The following is a description of a gene set: The chemical reactions and pathways resulting in the breakdown of mRNA, messenger RNA, which is responsible for carrying the coded genetic 'message', transcribed from DNA, to sites of protein assembly at the ribosomes. Mouse Gene Set: GOBP_MRNA_CATABOLIC_PROCESS studied in species Mus musculus, and this is the list of marker genes: Nrde2, Pcid2, Magohb, Pnldc1, Lsm2, Dnd1, Traf2, Exosc7, Mettl3, Dhx34, Ago4, Mrto4, Tent4b, Zfp36l1, Fastkd5, Rock1, Hnrnpr, Cnot10, Thrap3, Ncbp1, Cpeb3, Alkbh5, Mex3d, Pkp1, Igf2bp2 (insulin-like growth factor 2 mRNA binding protein 2), Arid5a, Fmr1, Caprin1, Upf1, Ttc5, Exosc6, Il17a, Qki, Ago1, Xrn1, Plekhn1, Myd88, Nbas, Rnasel, Hspa1a, Mov10, Mir466l, Mir451a, Gtpbp1, Trim71, Igf2bp3, Nanos2, Dhx9, Cirbp, Lsm14b, Apex1, Cnot1, Fxr2, Meioc, Angel2, Pym1, Mirlet7c-2, Rbm33, Skic2, Dcp1b, Tob1, Mtpap (mitochondrial poly(A) polymerase), Hnrnpd, Brf1, Magoh, Hnrnpu, Dicer1, Gspt1, Eif4enif1, Fus, Vip, Elavl4, Vim (NCBI Gene Id 22352), Elavl1, Slfn14, Larp1, Lsm4, Piwil2, Noct (nocturnin), Dis3l2, Nudt16l2, Tent5a, Zc3h12d, Rida, Tut7, Mirlet7c-1, Btg2, A1cf, Larp4b, Hspa1b, Tent4a, Dcp1a, Tent5c, Zar1, Tirap, Samd4, Mlh1, Rock2, Fastk, Tent5d, Etf1, Tnrc6a, Axin2, Eif4a3, Rnps1, Mir7578, Pabpc1, Gas5, Cacng7 (NCBI Gene Id 81904), Carhsp1, Npm1, Dcp2, Srsf1, Tnrc6b, Edc4, Hbs1l, Tut4, Gtpbp2, Smg7, Patl2, Pde12, Exosc5, Nudt16, Zfp36, Nudt12, Zhx2 (NCBI Gene Id 387609), Taf15 (TATA-box binding protein associated factor 15), Tbrg4, Tent2, Dazl, Zfp36l3, Cnot7, Slc11a1, Supv3l1, Smg1 (NCBI Gene Id 72492), Pum2, Pnrc1, Cnot2, Rbm24 (NCBI Gene Id 76176), Zc3hav1, Dis3l, Fam76b, Pum1, Ythdf3, Smg6, Eri1, Nicol1, Ssb, Igf2bp1, Cnot3, Eif4a3l2, Pcbp4, Hnrnpa0, Rbm38, Nudt16l1, Dis3, Upf3b, Ago2, Pias4, Fastkd3, Skic3, Calcr, Pnrc2, Smg8, Ctif, Mettl16, Ago3, Exosc9, Ythdf2, Dxo, Zc3h12a, Mir451b, Exosc2, Pnpt1, Fastkd1, Pabpn1l, Pkp3, Lsm6, Prr5l, Smg9, Ybx1, Exosc4, Nbdy, Tut1, Xrn2, Ythdf1, Mirlet7b, Zc3h14, Ncbp2, Mettl14, Piwil4, Fastkd2, Gtsf1, Dcps, Mir144, Skic8, Traf3ip2, Rc3h2, Mtor, Atm, Khsrp, Cnot8, Vegfa, Rbm10, Exosc8, Samd4b, Celf1, Patl1 (NCBI Gene Id 225929), Zfp36l2, Pelo (NCBI Gene Id 105236), Cnot9, Eif3e, Piwil1, Lsm5, Mapkapk2, Fxr1, Eif4a3l1, Polr2g, Apobec1, Dhx36, Hnrnpc, Gigyf2, Smg5, Hnf4aos, Ddx5, Syncrip, E2f1, Lsm7, Rbm46, Parn, Scgb1a1 (NCBI Gene Id 22287), Rbm8a2, Hnrnpab, Boll, Pan3, Secisbp2, Rbm8a, Ikbke, Ptbp1, Cnot6, Fto, Mir196a-2, Ybx2, Tardbp, Exosc3, Nanos3, Gdnf, Paip1, Tnrc6c, Edc3, Zcchc7, Gspt2, Tnf, Exosc10, Senp1, Upf3a, Cnot6l, Casc3, Snd1, Tent5b, Tesk1, Traf5, Rc3h1, Lsm1, Csdc2 (cold shock domain containing C2, RNA binding), Pan2, Mir196a-1, Pabpc4, Rbm47, Mir196b, Nanos1, Csde1, Upf2